The following is a description of a gene set: Genes predicted to be targets of miRBase v22 microRNA hsa-miR-1255b-2-3p in miRDB v6.0 with MirTarget v4 prediction scores > 80 (high confidence targets). studied in species Homo sapiens Human Gene Set: MIR1255B_2_3P from publication Chen Y, Wang X (PMID 31504780), and this is the list of marker genes: METTL4, MRE11 (NCBI Gene Id 4361), RBM12B, RND3, EIF5AL1, ROCK1, SMIM15, REPS1, SIMC1, DKC1, ACVR2B, ZCCHC12, NAA35, PLXNC1, RICTOR, PTGR1, IGF1 (insulin like growth factor 1), HES1, TAOK1, CFLAR, WASF3, PPM1E, NEK7, CXADR, PLS1, GYS2, MTUS2, NOTCH2, SLC25A35, YIPF4, STON2, ZMYM1, DOT1L, TAFA1, THOC7, TP53RK, USH2A, MTSS1, WDR44, GPC3, CDH11, TFAP2C, KRAS, ANAPC1, AGTR2, SHTN1, GPATCH2L, PHF20, GLRX2, RBP3, ZNF678, MAP4K3, RUFY2, BMPR2, EPN3, TRIM36, PTPRK, RAB5A, PHEX, TMEM68, ING1, PTCHD4, GTPBP10, CUL5, CLEC4M, TRNT1, PCGF5, PARPBP, SMARCE1, HSPA4L (heat shock protein family A (Hsp70) member 4 like), MRPS18C, RNF38, ZNRF3, MEF2A, EAF1, TMEM165, CISD2, TEAD1, PTBP3, MANEA, TXNDC5, CCNA2 (NCBI Gene Id 890), OXR1, ALG6, NLK, GPX8, LRRC3B, MAPK8, KLHL13